Given this list of marker genes Rrm2b, Pold2, Tex12, Pole2, Pold4, Rrm1, Cdkn2d, Pole, Poln, Sprtn, Polh, Polq, Sycp1, Pold3, Wrnip1, Dtl, Poldip2, Primpol, Hrob, Rev1, Sirt1, Trex1, Mad2l2, Pold1, Faap20, Vcp, Spata22 (spermatogenesis associated 22), Pclaf, Poli, Sycp3, Zbtb1, Polk, Pola1, Pcna, Rev3l, Wrn, Parp10, here is a description of the gene set: Mouse Gene Set: GOBP_DNA_SYNTHESIS_INVOLVED_IN_DNA_REPAIR Synthesis of DNA that proceeds from the broken 3' single-strand DNA end and uses the homologous intact duplex as the template. species: Mus musculus